The following is a description of a gene set: from publication Chen Y, Wang X (PMID 31504780) Genes predicted to be targets of miRBase v22 microRNA mmu_miR_7216_5p in miRDB v6.0 with MirTarget v4 prediction scores > 80 (high confidence targets). studied in species Mus musculus Mouse Gene Set: MIR_7216_5P, and this is the list of marker genes: Grem1, Rere, Ppfia4, Nfatc1, Flacc1, Lsm3, Car10, Ube2d3, Dtna, Patj, Tnfsf13, Snph, Ago1, Fkbp4, Kcne1, Pcdhb17, Grhl2, Rdh9, Ssbp2, Ppm1l, Cdc25b, Cltc, Mbtd1, Necap1, Cpeb3, Tlk1, Ikbkg, Cyp2b9, Tnrc6b, Lce1c, Fam107a, Zfp704, Nms, Dagla, S1pr3, Zc4h2, Aplp2, Nup50, Mucl3, Creb3l2, Stra6l, Ppp1r11, Mrgpra3, Npc1, Slc9a9, Adamts3, Tecr, Dpf2, Psat1, Thtpa, Syt1, Sun2, Rora, Hic2, Igf1r, Spcs2, Kcnc3 (potassium voltage gated channel, Shaw-related subfamily, member 3), Abi1, Sidt2, Nav1, Slc9a1 (solute carrier family 9 (sodium/hydrogen exchanger), member 1), Ctf1, Hsf5, Cgn, Cpeb4, Cep120, Dguok, Zswim6, Slc22a5, Pou4f2, Stxbp6, Lrrc7, Mfhas1, Ankfy1, Wdr20rt, Tmem263, Sptbn1, Jup, Fbxw11, Scgn (secretagogin, EF-hand calcium binding protein), Clstn1, U2af1l4, Clic1, Meis2, Mgll, Fndc9, Kcna1, Paqr8, Tnfsfm13, Dhrs11, Gfra1, Snx13, Il24, Ptger1, Cyp2b10 (cytochrome P450, family 2, subfamily b, polypeptide 10), Slc22a15, Tmprss2